Given this list of marker genes FLT3, FLT3LG, FYN, HCK, SYK, LCK, here is a description of the gene set: Reactome Pathway: FLT3 signaling through SRC family kinases Several SRC family kinases (SFKs) have been shown to interact with active FLT3 to modulate downstream signaling. These include FYN, HCK, LCK and SYK. The role of SFKs downstream of FLT3 is complex and not fully elucidated. Some family members appear to contribute positively to signaling, as assessed by elevated STAT5 signaling, while others may contribute to ubiquitin ligation and downregulation of the receptor through interaction with CBL. <br><br> species: Homo sapiens part of: FLT3 Signaling